Given this list of marker genes CTDP1, CTDSP2, SSU72L1, PPP2CA, SSU72L5, SSU72, SSU72L3, CTDSPL2, SSU72L4, PPP1CA, CTDSPL, SSU72L2, SSU72L6, RPAP2, CTDSP1, here is a description of the gene set: Human Gene Set: GOMF_RNA_POLYMERASE_II_CTD_HEPTAPEPTIDE_REPEAT_PHOSPHATASE_ACTIVITY Catalysis of the reaction: RNA polymerase II large subunit CTD heptapeptide repeat--phospho-L-serine/threonine (consensus YSPTSPS) + H2O = RNA polymerase II large subunit + phosphate. species: Homo sapiens